Given this list of marker genes Sdhc, Sdhd, Sdha, Sdhaf2, Sdhb, here is a description of the gene set: studied in species Mus musculus The transfer of electrons from succinate to ubiquinone that occurs during oxidative phosphorylation, mediated by the multisubunit enzyme known as complex II. Mouse Gene Set: GOBP_MITOCHONDRIAL_ELECTRON_TRANSPORT_SUCCINATE_TO_UBIQUINONE